Given this list of marker genes IFITM3, TPM2, SPARC, TFAP2B, TGFBI, SERPINF1, SFRP2, ECM1, SERPING1, CDH11, FGF7, NR2F2, PAX9, MGP, FBLN1, CCL2, CSRP2, TIMP1, THY1, GATA2, CALD1, APOD, C1R, GSN, TIMP2, COL3A1, MXRA8, LUM, CYP1B1, AEBP1, POSTN (NCBI Gene Id 10631), TFAP2A, CCN1, TPM1, C1S, TWIST1, ITGBL1, SSPN, VIM, SYNPO2, CLDN11, COL1A2, MFAP4, DCN, ENPP2, ABCA8, CCL11, CPE, TCIM, CRABP2, BGN, GJA1, GLIPR1, IGFBP4, SFRP1, TGM2, COL1A1, PGRMC1, PCOLCE, LAPTM4A, IGFBP5, CH25H, COL6A2, HGF, CCDC3, LGALS1, PTN, TMEM100, SELENOP, NBL1, KCNE4, ACTA2, INMT, PRRX1, RARRES2 (retinoic acid receptor responder 2), SELENOM, IGFBP6, TAGLN, CLEC11A, PLPP3, AKAP12, IGFBP7, here is a description of the gene set: Human Gene Set: DURANTE_ADULT_OLFACTORY_NEUROEPITHELIUM_FIBROBLASTS_STROMAL_CELLS studied in species Homo sapiens from publication Durante MA, Kurtenbach S, Sargi ZB, Harbour JW, Choi R, Kurtenbach S, Goss GM, Matsunami H, Goldstein BJ (PMID 32066986)